The following is a description of a gene set: Human Gene Set: GOBP_GLYCOSYLATION The covalent attachment and further modification of carbohydrate residues to a substrate molecule. studied in species Homo sapiens, and this is the list of marker genes: GFPT2, KRTCAP2, GBA1, ABO, B3GAT1, POMGNT1, DPY19L3, EXTL1, A4GNT, RPN2, MGAT4B, GCNT7, GOLGA2, ALG10, DERL3, GALNT8, TRAK1, B3GNT7 (UDP-GlcNAc:betaGal beta-1,3-N-acetylglucosaminyltransferase 7), STT3A, ALG5, COG3, COG5, COG8, ST6GALNAC4, POFUT2, ALG11, GORASP1, GALNT3, ST6GALNAC6, B3GALT9, UGGT2, B3GALT2, GMPPA, ALG8, GALNT18, PGM3, ST3GAL4, ACER2, B3GALT6, ST8SIA2, MAN2A1, MGAT4D, GAL3ST1, TET1, B3GALNT2, ALG3, B4GALNT1, B3GNT4, MOGS, ST6GALNAC1, EXT2, NANP, TMEM258, FUT10, ALG12, TMTC4, GBGT1, B4GALT6, B4GALT2, ST6GAL1 (ST6 beta-galactoside alpha-2,6-sialyltransferase 1), ST3GAL3, RAMP1, GFPT1, ST8SIA6, ALG13 (ALG13 UDP-N-acetylglucosaminyltransferase subunit), MGAT2, FUT5, AQP11, B4GALT4, DPY19L1, GXYLT1, MAN1A1, NPC1, GNE, GALNT4, FKRP, POGLUT2, CMAS, GALNT12, DOLPP1, CRPPA, NAGPA, EOGT, FUT1, MAN2A2, RFT1, SLC35C2, ALG14, PLOD1 (procollagen-lysine,2-oxoglutarate 5-dioxygenase 1), MGAT3, ST6GALNAC3, B3GNT8, ST3GAL2, ST3GAL5, ST6GALNAC2, PLOD3, ALG1, B4GALT5, GLT6D1, OGA, GRM7, A3GALT2, GMPPB, B3GNT3, FUT2, POMK, GALNT13, POFUT1, SLC39A8, GALNT10, B4GAT1, MAN1A2, GALNT11, VEGFB, NUDT14, COG2, CHP1, GALNT15 (NCBI Gene Id 117248), GALNT1, B3GALNT1 (beta-1,3-N-acetylgalactosaminyltransferase 1 (Globoside blood group)), B4GALNT2, B3GAT3, PMM1, GCNT2, B3GNT5, MGAT1, DAD1, GBA2, POMT2, PMM2, FREY1, ST3GAL1, POMGNT2, RXYLT1, GCNT4, TET2, GALNT5, B3GALT5, FUOM, MAGT1, EXT1, EXTL3, ABCA2, B3GALT4, FUT3, STT3B, B3GALT1, DDOST, OGT, MPDU1, GALNT14, ALG2, UGGT1, PSEN1, GCNT3, DTWD2, B4GALT3, SLC35C1, B4GALT7, ARFGEF1, TMEM165, FUT9, FUT8, C20orf173, TRAK2 (NCBI Gene Id 66008), SLC51B, RPN1, TET3, POGLUT3 (NCBI Gene Id 143888), GALNTL6, LMF1, TMTC1, TRIP11, CHST4, TMTC3, ST8SIA4, LARGE1, ST8SIA1, B3GNT9, COG1, MAN1B1, C1GALT1, OST4, GALNTL5, DHDDS, ST6GAL2, UBE2J1, MGAT4C, COLGALT1, GALNT6, GALNT9 (NCBI Gene Id 729185), PLOD2, DPM3, MGAT4A, FKTN, ST6GALNAC5, GCNT1, DPM1, NUS1, MGAT5, ALG6, ALG1L2, C1GALT1C1, XXYLT1, POGLUT1, COG6, FUT4, ALG9, FUT6, B3GAT2, NANS (N-acetylneuraminate synthase), GXYLT2, GALNT7, B3GNT2, SRD5A3, B3GNT6, COG7, TMEM260, OSTC, GALNT16, ST8SIA3, SERP1, FUT7, ST3GAL6, EDEM3, TMTC2, B4GALT1, FUT11, GALNT2, COG4, MGAT5B, CLN5, ENTPD5, CCDC134, GALNT17, DOLK, ST8SIA5, CWH43, B3GLCT, MAN1C1, TUSC3, POMT1, DPAGT1, TMEM59, DPM2, LARGE2, ALG10B